The following is a description of a gene set: Any process that stops, prevents or reduces the frequency, rate or extent of an oxidative stress-induced intrinsic apoptotic signaling pathway. species: Mus musculus Mouse Gene Set: GOBP_NEGATIVE_REGULATION_OF_OXIDATIVE_STRESS_INDUCED_INTRINSIC_APOPTOTIC_SIGNALING_PATHWAY, and this is the list of marker genes: Fgf2, Gata4, Atf4, Park7, Prkn, Rack1, Nono, Wnt1 (wingless-type MMTV integration site family, member 1), Fzd1, Pycr1, Fbxo7, Gpx1, Nol3, Ppia, Hspb1, Pink1, Fyn, Nme5, Sirt1, Trap1, Bag5, Hif1a, Nfe2l2, Sod2, Il10, Ctnnb1, Mapk7